Given this list of marker genes Tbx5, Hoxd11, Ark2c, Runx2, Alx4, Ift122, Sall1, Fmn1, Sall3, Hoxa13, Osr1, Atrx, Crabp2, Wnt3, Rpgrip1l, Mecom, Ctnnb1, En1, Aldh1a2, Rdh10, Gdf5, Lnpk, Shh, Reck, Trp63, Hoxd10, Tfap2b, Zbtb16, Cacna1c, Hoxa9, Osr2, Wnt7a, Twist1, Rspo2, Msx2 (msh homeobox 2), Vps54, Tfap2a, Alx3, Nipbl, Enpp1, Hoxd9, Hoxa11, Msx1, Tbx3, Lrp6, Wnt9a, Shox2, here is a description of the gene set: Mouse Gene Set: GOBP_FORELIMB_MORPHOGENESIS The process in which the anatomical structures of the forelimb are generated and organized. The forelimbs are the front limbs of an animal, e.g. the arms of a human. species: Mus musculus